The following is a description of a gene set: Mouse Gene Set: SATB2_TARGET_GENES from publication Yevshin I, Sharipov R, Kolmykov S, Kondrakhin Y, Kolpakov F (PMID 30445619) studied in species Mus musculus Genes containing one or more binding sites for (Satb2) in their promoter regions (TSS -1000,+100 bp) as identified by GTRD version 20.06 ChIP-seq harmonization., and this is the list of marker genes: Mta2, Lman1, Acin1, 9930004E17Rik, Sox5, Creb1, Notch4, Dab2ip, Extl3, Deaf1, Brsk2, Armc8, Snx12, Tmem80, Speer4cos, Wac, Ikbkg, Inpp4b, Abca4, Pigyl, Pex2, Gm16291, Ube2m, Cenpu (NCBI Gene Id 71876), Gdpd5, U2af2, Kdm3a, Pde12, Arhgap17, Rabep2, Atp5mg (ATP synthase membrane subunit g), Fam3a, Yipf6, Pipox, Mir7672, Ppp1r37, Tada1, Tcf4, Myl4, Gm816, H4c11, Pank2, 5830416I19Rik, Kmt2a, Tbc1d9b, Lclat1, Bclaf1, Zbtb20, Mark2, Ano6 (anoctamin 6), Kctd5, Gipc1, Cdc27, Ski, Tspan6, Impa1 (NCBI Gene Id 99601), Etnk1, Gm3764, Csnk1g3, Ate1, Ino80, 1700023G09Rik (NCBI Gene Id 73281), Ercc4